The following is a description of a gene set: Genes up-regulated in comparison of thymus regulatory T cells versus fat tissue regulatory T cells. Human Gene Set: GSE7852_THYMUS_VS_FAT_TREG_UP studied in species Homo sapiens from publication Feuerer M, Herrero L, Cipolletta D, Naaz A, Wong J, Nayer A, Lee J, Goldfine AB, Benoist C, Shoelson S, Mathis D (PMID 19633656) Comparisons of global gene-expression profiles revealed a greater distinction between CD4+ Treg cells and CD4+ conventional (Tconv) T cells residing in abdominal (epidydimal) fat versus in more standard locations such as the spleen, thymus and LN., and this is the list of marker genes: TRAPPC5, DTX3L, PPHLN1, POLR2D, PUS7, RMDN1, ZNF229, ADH5, GUF1, CELSR1, ATPSCKMT, CALHM6, TTLL4, SCAI, BRMS1L, PNISR, LUC7L3, ZBTB9, HCFC2, CD47, GTF2A2, IREB2, TMEM258, GMCL1, MRPL35, EFCAB7, TADA1, CSTF3, C2orf69, CCR6, MRPL50, SUOX, PAPSS1, ADGRL1, AGO1, ELMOD2, SMC4, RNF38, BCAS2, IGSF3, TP53RK, KTI12, TRMT6, KLHL9, PPCS, COIL (NCBI Gene Id 96825), LMAN2L, ABCD3, CHCHD10 (NCBI Gene Id 400916), PDHX, PRICKLE1, E2F3, FAM91A1, ITGB3BP, ARMC1, ZNF512, C9orf85 (chromosome 9 open reading frame 85), STAT5B, TCEANC, DPH5, PTCD3 (NCBI Gene Id 55037), ITGAE, CEP68, RABEPK, NUBPL, ABCG1, TTC28, TMEM229B, PIGC, ACTR6, KIAA1143, WDR73, FBXO32, ZDHHC16, CETN3, PSMA2, DPH6 (diphthamine biosynthesis 6), DCK, ST6GAL1, METTL6, SMARCAD1, POLR3G, ZSWIM1, ATF1, HPRT1, LEF1, RDH14, BTLA, HYPK, ENOX2, TCF7, SIRT3 (sirtuin 3), DNAI4, MPHOSPH8, EDC3, PDF, RWDD1 (NCBI Gene Id 82733), POLR2H, GYPC, BCS1L, SFXN4, PPIA, PSMA6, PIGX, GOLM2, DRG1, NNT, DFFB, MTF2, NANP, ZGRF1, EFCAB2, ZNF329, ECHS1, C2orf68, KLHDC2, METTL18, MLLT11, ZNF799, SCYL3, DZIP1, PSMG4, MTCH2, DCUN1D5, GOSR2, SGK3, ANKRD39, CCND3, MPLKIP, TXNDC15, CCR7, BDH1, CHAMP1, CSTF2, RPRD1A, N4BP2, DIMT1, NDUFAF1, MRPL11, BRD8, BCL2, OSTC, FKTN, SPICE1, CNOT2 (NCBI Gene Id 51498), VCP, CD1D, CCNH, ZNF43, ICE2, SEPHS1, THEMIS, PHF10, PPP1R7, ATP5PB, HDAC7, MRPL39, TRIB3, UFM1, PPIL3, TXK, YEATS4, TIMM22, PSMG2, PGP, RFESD (NCBI Gene Id 317671), ST8SIA6, AP3M1, EVL (Enah/Vasp-like), ASXL1, DEXI, TARS2, TRAPPC12, EXOC6, CDC16, MRPL27, ANKMY2, CBL, NIT1, RFX7, ZNF141, FAF2, ZBTB5, SEC23IP, IGF1R (insulin like growth factor 1 receptor), VAMP5, BRD7, USP40, CEP19, ATP6V0A2, PLEKHG2, GATAD1, PDCD7, FAM234B, JARID2, SLC25A14, RTP4, TUBG1 (tubulin gamma 1), REXO2, ARHGAP20